The following is a description of a gene set: species: Homo sapiens Human Gene Set: GOBP_MACROPHAGE_APOPTOTIC_PROCESS Any apoptotic process in a macrophage, a mononuclear phagocyte present in a variety of tissues., and this is the list of marker genes: PLEKHO2, CTSL, MEF2C, SELENOS, CCR5, CDKN2A (NCBI Gene Id 1029), CCL5, MIRLET7B, NOD2, GHSR, IRF3, IRF7, SIRT1